Given this list of marker genes COMT, GP1BB, ARVCF, CASR, CYP2R1, RREB1, RRAGD, KCNJ1, PTH, TRPM6, SEC24C, TBCE (NCBI Gene Id 6905), CYP27B1, SLC12A1, TCIRG1, SLC12A3, JMJD1C, UFD1, HIRA, GATA3, TBX1, CLDN16, here is a description of the gene set: Human Gene Set: HP_TETANY A condition characterized by intermittent involuntary contraction of muscles (spasms) related to hypocalcemia or occasionally magnesium deficiency. Tetany species: Homo sapiens